Given this list of marker genes KIR3DL1, KIR2DL1, LAIR2, FGFBP2, S1PR5, PRSS23 (serine protease 23), RASSF4, GZMH (granzyme H), CX3CR1 (C-X3-C motif chemokine receptor 1), GZMB, GNLY, SPON2, FCRL6, KIR2DL3, MYOM2, RAP1GAP2, ZEB2, ADGRG1, here is a description of the gene set: CD16+ NK from publication He P, Lim K, Sun D, Pett JP, Jeng Q, Polanski K, Dong Z, Bolt L, Richardson L, Mamanova L, Dabrowska M, Wilbrey-Clark A, Madissoon E, Tuong ZK, Dann E, Suo C, Goh I, Yoshida M, Nikolić MZ, Janes SM, He X, Barker RA, Teichmann SA, Marioni JC, Meyer KB, Rawlins EL (PMID 36493756) studied in species Homo sapiens Human Gene Set: HE_LIM_SUN_FETAL_LUNG_C4_CD16_POS_NK_CELL